The following is a description of a gene set: species: Homo sapiens Genes predicted to be targets of miRBase v22 microRNA hsa-miR-4776-3p in miRDB v6.0 with MirTarget v4 prediction scores > 80 (high confidence targets). from publication Chen Y, Wang X (PMID 31504780) Human Gene Set: MIR4776_3P, and this is the list of marker genes: LRAT, SLC30A8, NWD1, ALOX15, JADE1, HAUS2, ZNF793, NR3C1, ENTHD1, PHF6, PCDHA5, GLYR1, RAD23B, LUZP1, PCDHA3, GARIN6, SYT2, GOLPH3, ZNF611, PTCHD4, CNTN5, ZNF208, DPYSL2 (NCBI Gene Id 1808), PAQR5, ZNF117, ZNF676, ARHGAP32, C18orf63, PCDHA10, PCDHA13, ZNF737, APPL2, CFL2, FBXO22, CLHC1, ZNF506, ZNF816, CCDC88A, RUNX2, AMOTL1, PCDHA12, ZNF468, RASSF3, MARCHF11, RAB3C, ZNF880 (NCBI Gene Id 400713), MSL3, PCDHA11, VEPH1, HMGXB4, RARB, KCTD4, SP100, PCDHAC1, ZFP28, ZNF107, RAN, ZNF714, AFF4, RAD51D, PCDH9, GGNBP2, YTHDF3, ESYT3, HOOK1, ZNF99, EIF5A2, ZNF730, PCDHA9, EBF1, FAM135B, ANGPT1, TENT5D, ARHGAP11A, IGF2BP3, PPIL4, SLC16A7, ACTL10, GDI2, SALL1, AGO3, USP25, SIAH1, ZNF329, PTGES3, SDC1, TRIM45, CUL3, STRN, RNF169, PCDHA1, BICC1, LBH, GAP43, PEX5L, ZNF322, TRA2B (NCBI Gene Id 6434), SLC35F1, ATG2B (autophagy related 2B), PCDHA6, ZNF195, ZNF732, C5orf15, RRAGD, SRSF2, ARGFX, ZNF667 (zinc finger protein 667), GLIPR1L2, USH2A, ZBTB2, ZNF600, TMEM19, IQSEC3, LRRC8B, MTMR9, TBCEL, RP2, ZNF431, CADM2, ARF1, ZNF708, ZNF100, ZNF578, ZNF728, TACR1, PCDHA2, ATG4B, HMGN1, ZNF709, SDC2, TUBB1 (NCBI Gene Id 81027), C5AR1, ADAT2, CXCL5, TRIM14, CSAD, PAK5, TAX1BP1, PREX2, FZD3, PCDHA4, HYPK, PCDHA7, NR4A3, ZNF138, ZNF493, MARCHF7, TRIM33 (NCBI Gene Id 80027), EXD2, KIAA2013, CUL2, POLK, DEPDC4, CCDC68, CLIC2, PCDHAC2, TPRG1, COL11A1, FGF23, PCDHA8, STRBP (spermatid perinuclear RNA binding protein)